Given this list of marker genes RECQL5, RAD51, FANCB, RAD21L1, NIPBL, RAD21, here is a description of the gene set: Human Gene Set: GOBP_REPLICATION_BORN_DOUBLE_STRAND_BREAK_REPAIR_VIA_SISTER_CHROMATID_EXCHANGE species: Homo sapiens The repair of a replication-born double-strand DNA break in which the DNA molecule is repaired using the homologous sequence of the sister chromatid which serves as a template to repair the breaks.